The following is a description of a gene set: from publication Chen Y, Wang X (PMID 31504780) Human Gene Set: MIR6878_3P Genes predicted to be targets of miRBase v22 microRNA hsa-miR-6878-3p in miRDB v6.0 with MirTarget v4 prediction scores > 80 (high confidence targets). species: Homo sapiens, and this is the list of marker genes: NTNG1, AR, LCE3E (NCBI Gene Id 353145), BSN, COL5A1, REST, IL17RD, CNOT6, LUM, NPTXR, BACH2, ALG11, SLC38A2, INHBB, MINDY2, SENP6, TOR4A, EIF1, SH3KBP1, TRIM39, H2BC21, NRBP2, TAF8, CREM, RGS4, IGF1, PRKCA, TPI1, SMIM18, GEM, DAO, NAGA, CACNA2D4, TSC1 (TSC complex subunit 1), ONECUT2, GIPC3, LXN, BBX, FANCD2, S1PR1, SLAIN2, NKAIN2, DCUN1D4, SYDE2, DST, TMEM178B, TMEM217, CCL22, SHH, JADE3, NVL, PTCH1, GGTLC2, NCAPG, EVX1, RAP1GAP2, EMILIN3, STK33, PPME1, ELAVL3, CDK14, NCS1, SEPSECS, DNAJC24, AFG1L, F2RL3, MLKL, PRR11, NIPAL1